Given this list of marker genes Pdpr, Sirt4, Pkm, Gid4, Pdha1, Ubb, Dld, Armc8, Ldha (NCBI Gene Id 16828), Dlat, Gstz1, Rps27a, Pdp1, Pdk4, Rmnd5b, Pgam5, Ranbp9 (RAN binding protein 9), Pdk2, here is a description of the gene set: studied in species Mus musculus electronically inferred by orthology from the curated human pathway This event has been computationally inferred from an event that has been demonstrated in another species.<p>The inference is based on the homology mapping from PANTHER. Briefly, reactions for which all involved PhysicalEntities (in input, output and catalyst) have a mapped orthologue/paralogue (for complexes at least 75% of components must have a mapping) are inferred to the other species. part of: Pyruvate metabolism Reactome Pathway: Regulation of pyruvate metabolism